The following is a description of a gene set: Reactome Pathway: Defective SLC17A8 causes autosomal dominant deafness 25 (DFNA25) There are two classes of glutamate transporters; the excitatory amino acid transporters (EAATs) which depend on an electrochemical gradient of Na+ ions and vesicular glutamate transporters (VGLUTs) which are proton-dependent. Together, these transporters uptake and release glutamate to mediate this neurotransmitter's excitatory signal and are part of the glutamate-glutamine cycle. Three members of the SLC17A gene family (7, 6 and 8) encode VGLUTs 1-3 respectively. This uptake is thought to be coupled to the proton electrochemical gradient generated by the vacuolar type H+-ATPase. They are all expressed in the CNS in neuron-rich areas but SLC17A8 (VGLUT3) is also expressed on astrocytes and in the liver and kidney. Defects in SLC17A8 can cause autosomal dominant deafness 25 (DFNA25; MIM:605583), a form of non-syndromic sensorineural hearing loss. The cochlea expresses SLC17A8 and in mice which lack this transporter are congenitally deaf. Hearing loss is due to the lack of glutamate release by inner hair cells therefore a loss of synaptic transmission at the IHC-afferent nerve synapse. Successful restoration of hearing by gene replacement in mice could be a significant advance toward gene therapy of human deafness. part of: SLC transporter disorders species: Homo sapiens, and this is the list of marker genes: SLC17A8